The following is a description of a gene set: Genes up-regulated in comparison of B cells from TIV influenza vaccinee pre-vaccination versus those at day 7 post-vaccination. Systems vaccinology has emerged as an interdisciplinary field that combines systems wide measurements and network and predictive modeling applied to vaccinology. Here we used the systems vaccinology approach to study the molecular mechanisms underlying th from publication Nakaya HI, Wrammert J, Lee EK, Racioppi L, Marie-Kunze S, Haining WN, Means AR, Kasturi SP, Khan N, Li GM, McCausland M, Kanchan V, Kokko KE, Li S, Elbein R, Mehta AK, Aderem A, Subbarao K, Ahmed R, Pulendran B (PMID 21743478) Human Gene Set: GSE29618_PRE_VS_DAY7_POST_TIV_FLU_VACCINE_BCELL_UP species: Homo sapiens, and this is the list of marker genes: POU1F1 (NCBI Gene Id 5449), PREX2, NF1, PGR, CDO1, SLCO1C1, TMEM50B, PARVA, IGFBP4, TRIM10, HR (NCBI Gene Id 55806), DNM1, CCNP, NPTX2, ZFTRAF1, FZD4, PEG3, CFHR5, STARD13, TBXT, PPP1R3A, KRT6B (NCBI Gene Id 3893), MTUS2, LGR5, GAS6, PTPN4, ZMAT3, MSX2, NPY4R, TBL1XR1, DHX29, MLH1, WNT2B, CHRNB3, TTC39A, CPNE7, NEIL3, MRPS18C, PTPN14, LINC02249 (long intergenic non-protein coding RNA 2249), CGA, NR5A1, AKR1C3, ADGRB3, LRP6, CLEC4M, AMELX, GRIA2, GRIK5, C1orf21, PHLDA3, CPA3, CPZ, SPP1, PPP1R13L, H1-6, ADH7 (NCBI Gene Id 131), IL5RA, CD5L, SERPINA7, SFRP5, CTNND2, S100B, HIGD1B, NDRG4, SERPINA6, PHEX, ISLR, MYCT1, CUBN, ADAM7, MAGEA11, NLRP2, TAC1, BBC3, SFT2D2, SLC24A2, PCLO, MATCAP2, SV2A, KIF2C, CMA1, SIX2, CSH2, MSTN, EPCAM, CTRC, MYBPC2, PYY, KRT17, MUC13, ZBTB3, NPY1R, DKKL1, RPL13P5, TRIM25, EBP, MYBPC3, AP1M2, PDCD1, GPR35, MYOZ3, TEAD3, CACNG5, RPS6KB1, TCAP (NCBI Gene Id 8557), HOXB3, AJAP1 (NCBI Gene Id 55966), LORICRIN, KCNA10, CSPG4, KRT23, CFH (NCBI Gene Id 3076), PCDH1, SPINT3, AVPR2, PGPEP1, WT1, GABRP, ACKR2, FZD8, TMEM120B, RAB11FIP4, AQP4, EDNRA, ZNF124, OR7E87P, SH3BP1, SPTBN4, OLFML2A, BAAT, ARHGEF4, BRD7P3, CCR4, HIF3A, ZNF14, ASIC1, MSC, ZNF180, HAND1, KCNN3, HROB, NELL1, ARHGAP44, HOXD11, SNPH, NDRG2, RUNDC3A, PNLIPRP2, NRG1, KCNS3, CCN4, YIPF5, NAT8B, CDH6, THNSL2, MAGEB1, HAPLN1, OLFM1, ST8SIA3, CNGA1, PBX3-DT, KRT3, SFTPD, BGN, GIPR, ALOX15, BSPRY, BRME1, TENM1, CFAP74, ADRA1B, GDAP1L1, ADCY2, CRABP2, ECE2, B3GNTL1, IRF6, CTTN, THAP7, SLC19A1, CCR3, SOCS2, ID4, H3-4, RNF144A, ZNF282, RBP1, NUBPL, IL11, SLC6A14, UPK3B, RARB, NECAP1, TUSC3, F11, FAT4